The following is a description of a gene set: studied in species Mus musculus A protein complex formed by the association of several methylated Sm proteins with the SMN complex; the latter contains the survival motor neuron (SMN) protein and at least eight additional integral components, including the Gemin2-8 and unrip proteins; additional proteins, including galectin-1 and galectin-3, are also found in the SMN-SM complex. The SMN-Sm complex is involved in spliceosomal snRNP assembly in the cytoplasm. Mouse Gene Set: GOCC_SMN_SM_PROTEIN_COMPLEX, and this is the list of marker genes: Snrpd1, Gemin6-ps, Snrpert, Snrpf, Gemin4, Strap, Snrpd3, Gemin2, Gemin8, Ddx20, Snrpe, Gemin7, Fmr1, Gemin6, Snrpb, Snrpg, Smn1, Snrpd2, Gemin5